The following is a description of a gene set: Combining with a complex of transforming growth factor beta and a type II TGF-beta receptor to initiate a change in cell activity; upon binding, acts as a downstream transducer of TGF-beta signals. Human Gene Set: GOMF_TRANSFORMING_GROWTH_FACTOR_BETA_RECEPTOR_ACTIVITY_TYPE_I studied in species Homo sapiens, and this is the list of marker genes: TGFBR1, ACVR1 (activin A receptor type 1), BMPR1A, BMPR1B, ACVRL1